Given this list of marker genes Trp53, Slit3, Pdyn, Zfp36, Mapk1, Btg2, Prkca, Cspg4, Gadd45a, Rhoa (NCBI Gene Id 51787), Cxcl2, Slit1, Epha4, Ptpra, Pla2g6, Pirb, Col2a1, E2f5, Chst11, Xylt1 (xylosyltransferase 1), Icam1, Ptprz1, Mapk3, Sox9, Il2, Ccng1, Rtn4r, Arg1, Tnfsf13, Nr4a1, Col4a1, Acan, Fkbp1a, Il1b, Selp, Myc, Hc, Il1r1, Klk8 (kallikrein related-peptidase 8), Ppp3ca, Vim, Omg, Rhoc, Cd47, Cdk2, Casp3, Pla2g2a, Anxa1, Bdnf, Prb1a, Plxna2, Egr1, Nos1, Gap43, Rgma, Ltb, Rhob, Sema6a, Mbp, Nos2, Gdnf, Mmp12, Ngfr, Slit2, Ccnd1, Tlr4, Rb1, Rock2, Tnfsf13b, Cxcl1, Cdk1, Gja1, Ifng, Tacr1, Il6, Tgfb1 (NCBI Gene Id 21803), Ntn1, Ltb4r1, Bcan, Mag, Vcan, Grin1, Nox4, Il4, Tnf (tumor necrosis factor), E2f1, Cxcl10, Efnb2, Fcgr2b, Mmp9, Ccr2 (NCBI Gene Id 235692), Fos, Gfap, Ccl2 (C-C motif chemokine ligand 2), Rtn4, Ncan, Aqp4, Il1a, Pla2g5, here is a description of the gene set: species: Mus musculus Spinal cord injury Mouse Gene Set: WP_SPINAL_CORD_INJURY